The following is a description of a gene set: Enlargement of the wrists species: Homo sapiens Human Gene Set: HP_ENLARGEMENT_OF_THE_WRISTS, and this is the list of marker genes: CYP27B1, CYP2R1, ENPP1, CLCN5, VDR, AIFM1, SLC34A3, DMP1